The following is a description of a gene set: Human Gene Set: IGLESIAS_E2F_TARGETS_DN Genes down-regulated in pancreatic cells from mice with double knockout of E2F1 and E2F2 compared to wild type. species: Mus musculus from publication Iglesias A, Murga M, Laresgoiti U, Skoudy A, Bernales I, Fullaondo A, Moreno B, Lloreta J, Field SJ, Real FX, Zubiaga AM (PMID 15146237) E2F transcription factors are thought to be key regulators of cell growth control. Here we use mutant mouse strains to investigate the function of E2F1 and E2F2 in vivo. E2F1/E2F2 compound-mutant mice develop nonautoimmune insulin-deficient diabetes and exocrine pancreatic dysfunction characterized by endocrine and exocrine cell dysplasia, a reduction in the number and size of acini and islets, and their replacement by ductal structures and adipose tissue. Mutant pancreatic cells exhibit increased rates of DNA replication but also of apoptosis, resulting in severe pancreatic atrophy. The expression of genes involved in DNA replication and cell cycle control was upregulated in the E2F1/E2F2 compound-mutant pancreas, suggesting that their expression is repressed by E2F1/E2F2 activities and that the inappropriate cell cycle found in the mutant pancreas is likely the result of the deregulated expression of these genes. Interestingly, the expression of ductal cell and adipocyte differentiation marker genes was also upregulated, whereas expression of pancreatic cell marker genes were downregulated. These results suggest that E2F1/E2F2 activity negatively controls growth of mature pancreatic cells and is necessary for the maintenance of differentiated pancreatic phenotypes in the adult., and this is the list of marker genes: GNMT, NNT (NCBI Gene Id 23530), LORICRIN, PRSS2, IGF1, H1-2, DMBT1, SYT3, MT1F (metallothionein 1F), REG3A, CEL, MT1X, CASP9, ITIH4